The following is a description of a gene set: Cytokines mediate cell-cell communication in the immune system and represent important therapeutic targets. A myriad of studies have highlighted their central role in immune function, yet we lack a global view of the cellular responses of each immune cell type to each cytokine. To address this gap, the authors created the Immune Dictionary, a compendium of single-cell transcriptomic profiles of more than 17 immune cell types in response to each of 86 cytokines (>1,400 cytokine-cell type combinations) in mouse lymph nodes in vivo. A cytokine-centric view of the dictionary revealed that most cytokines induce highly cell-type-specific responses. For example, the inflammatory cytokine interleukin-1β induces distinct gene programmes in almost every cell type. A cell-type-centric view of the dictionary identified more than 66 cytokine-driven cellular polarization states across immune cell types, including previously uncharacterized states such as an interleukin-18-induced polyfunctional natural killer cell state. Mouse Gene Set: CUI_CDC2_ADIPONECTIN_RESPONSE_UP species: Mus musculus Genes positively differentially expressed in cell type: cDC2 (conventional dendritic cell type 2) upon treatment with cytokine: AdipoQ in mouse lymph nodes in vivo. from publication Cui A, Huang T, Li S, Ma A, Pérez JL, Sander C, Keskin DB, Wu CJ, Fraenkel E, Hacohen N (PMID 38057668), and this is the list of marker genes: Ptpn1, H2-Q7, Slc25a5, Rab7, Lap3, Clec12a, Ldha, Pltp, Aldoa, Ak2, Tmem106a, Ccr2 (NCBI Gene Id 235692), Ly86, Cfb, Ewsr1, Pld4, Trafd1, Tnfrsf1b, C3, Ifngr1, Nr1h3, Clec4n, Tpi1 (NCBI Gene Id 21991), Clec4a1, H2-T23, Lbh, M6pr, Mfsd1, Tuba1b, Nap1l1, Ncf2, Arl5a, Rab11a, Vcam1, Cxcl16, Pfdn1, Ptpn7, Sf3b3, Dazap2 (NCBI Gene Id 23994), Psmb8, Pla2g7, Mcub, Znfx1, Colgalt1, Mif